The following is a description of a gene set: species: Homo sapiens Human Gene Set: HP_CONTRACTURE_OF_THE_DISTAL_INTERPHALANGEAL_JOINT_OF_THE_FINGERS Contracture of the distal interphalangeal joint of the fingers Chronic loss of joint motion in one or more distal interphalangeal joints of the fingers., and this is the list of marker genes: SOX9, KMT2A, LMX1B, SIN3A, IDUA, TOR1AIP1